Given this list of marker genes Fn1, Adam9, Hyal2, Foxp1 (forkhead box P1), Lilrb4b, Lilrb4a, Npy, Adam10, Dysf, here is a description of the gene set: Mouse Gene Set: GOBP_MONOCYTE_ACTIVATION species: Mus musculus The change in morphology and behavior of a monocyte resulting from exposure to a cytokine, chemokine, cellular ligand, or soluble factor.